The following is a description of a gene set: Catalysis of an oxidation-reduction (redox) reaction in which a CH-CH group acts as a hydrogen or electron donor and reduces NAD or NADP. Human Gene Set: GOMF_OXIDOREDUCTASE_ACTIVITY_ACTING_ON_THE_CH_CH_GROUP_OF_DONORS_NAD_OR_NADP_AS_ACCEPTOR studied in species Homo sapiens, and this is the list of marker genes: PTGES2, FASN, PTGR3, MECR, DECR2, BLVRA, DUS1L (NCBI Gene Id 64118), AKR1C2, DHDH, SRD5A1, PTGR1, PTGR2, DUS4L, LBR, DHCR7, BLVRB, AKR1D1, TBXAS1, TECR, AKR1C3, DUS3L, DUS2, AKR1C1, DHRSX, SRD5A3, SRD5A2 (NCBI Gene Id 6716), TM7SF2, DHCR24, PECR, DECR1, CYP2S1, BDH2, DPYD